Given this list of marker genes SNX10, AHNAK (AHNAK nucleoprotein), ACOT7, SLC4A1AP, MICAL1, CUTA, TNFSF14, ODC1, GIMAP7, MYADM, CPD, PRKX, DDX28, CEACAM3, BTF3, KCNIP3, DACH1, ATF6, SERPINB9, IL18RAP, CALM2, CHCHD2, SYPL1, FGL2, SMPDL3B, CRYBG1, CST3, SLC4A7 (NCBI Gene Id 9497), HIP1, PTPRJ, RHEB, CYRIA, HSF4, TTC39B, GPR160, EMP1, IRAK3, RBM47, RPL39L, COX8A, GGH, RUNX2, NUDT4, AP3S1, NFIL3 (nuclear factor, interleukin 3 regulated), CD38, PLEKHF1, S1PR5, MRPS24, GABARAPL2 (NCBI Gene Id 90769), RGS1, FAM107B, PRKAR2A, SMNDC1, ZEB2, APOBEC2, IFT20, PHF11, LRRFIP2, BAG3, F2R, ARHGAP26, NDUFA1, NKG7, HTATIP2, ELOB, RORA, GBP3, CST7, RILPL2, COQ10B, YBX3, SCRN3, THEMIS2, INSL6, REEP5, AIF1, MYO1F, CXCR3, SYT7, IL18R1, GADD45B, GABARAPL1, BSPRY (B-box and SPRY domain containing), TCEAL9, IFNGR1, PTTG1, ASRGL1, PAWR, CYSLTR2, ANXA1, SNX5, GZMM (granzyme M), NR1D2, RGS2, CX3CR1, PPM1J, H2BC4, CCL4, SYS1, KLRC2, NR2F6, BLVRA, P2RY10, CD28, LY6H (lymphocyte antigen 6 family member H), ATP6V1G3, FCGR2B, DUSP5, GALNT3, TBX21, H1-2, AP1S2, COBLL1, CHSY1, CARHSP1, HIF1A, ZYX, GEM, PERP, ANXA4, NDUFS6, REEP3, ITGB1, SPTY2D1, IL12RB2, S100A11, PRDM1, GPANK1, STARD10, CXCR6, PRF1, HACD2 (3-hydroxyacyl-CoA dehydratase 2), SEPTIN4, GSAP, RAP2A, S100A9, PHLDA1, PLSCR1, S100A13, ABHD5, GNA15, PTGES2, LAIR1, SUB1, NCALD, ECH1, DMRTA1 (DMRT like family A1), SRGN, PTPN13, ALCAM, MPHOSPH6, PMAIP1, KCNJ8, SDF2L1, SCFD2, ATP5F1E, CASP1, S100A8, GTF2F2, ARHGAP18, ATG5, ATP2B4, HOXC11, ELL2, UBE2N, BAG1, ZWINT (NCBI Gene Id 11130), OAT, ACADL, NIBAN1, HOPX, HSPA1A, ITGAX, NPTN, TXNDC17, CD44, FTH1, here is a description of the gene set: Human Gene Set: GSE13946_CTRL_VS_DSS_COLITIS_GD_TCELL_FROM_COLON_UP Genes up-regulated in gamma delta intraepithelial lymphocytes from colon: control versus colitis induced by dextran sulfate sodium (DSS). studied in species Homo sapiens from publication Ismail AS, Behrendt CL, Hooper LV (PMID 19234201) gamma delta intraepithelial lymphocytes were isolated from the colons of DSS-treated and untreated mice. Total RNAs were isolated and compared by Affymetrix DNA microarray.